The following is a description of a gene set: The presence of a left and a right superior vena cava. species: Homo sapiens Human Gene Set: HP_BILATERAL_SUPERIOR_VENA_CAVA Bilateral superior vena cava, and this is the list of marker genes: SMAD2, CWC27, ZIC3, ACVR2B, CIROP, LRPPRC, SLC29A3, MED25, FADD, NCAPG2 (non-SMC condensin II complex subunit G2), CFC1, PRKACB (NCBI Gene Id 5567)